The following is a description of a gene set: Genes containing one or more binding sites for (SIGMAR1) in their promoter regions (TSS -1000,+100 bp) as identified by GTRD version 20.06 ChIP-seq harmonization. species: Homo sapiens Human Gene Set: SIGMAR1_TARGET_GENES from publication Yevshin I, Sharipov R, Kolmykov S, Kondrakhin Y, Kolpakov F (PMID 30445619), and this is the list of marker genes: EEF1A1, MTCO3P12, EP300, MAPK8IP2, SNAP25-AS1, HTR5A, CHRNB2, SCRT1, RNPS1, GLRA1, CARMIL2, MIR3677HG, PLSCR4, MIR7-3HG, MIR7-3